Given this list of marker genes Atad2, Esr1, Cga, here is a description of the gene set: This event has been computationally inferred from an event that has been demonstrated in another species.<p>The inference is based on the homology mapping from PANTHER. Briefly, reactions for which all involved PhysicalEntities (in input, output and catalyst) have a mapped orthologue/paralogue (for complexes at least 75% of components must have a mapping) are inferred to the other species. species: Mus musculus Reactome Pathway: TFAP2 (AP-2) family regulates transcription of growth factors and their receptors electronically inferred by orthology from the curated human pathway part of: Transcriptional regulation by the AP-2 (TFAP2) family of transcription factors